The following is a description of a gene set: species: Homo sapiens The chemical reactions and pathways involving purine nucleobases, one of the two classes of nitrogen-containing ring compounds found in DNA and RNA, which include adenine and guanine. Human Gene Set: GOBP_PURINE_NUCLEOBASE_METABOLIC_PROCESS, and this is the list of marker genes: PPAT, URAD (NCBI Gene Id 651560), GART, PRTFDC1, PRPS1, TTR, GMPS, APRT, ADK, GMPR2, PAICS, GDA (NCBI Gene Id 9615), KDM1A, DPYD, ADA, ACP3, SHMT1, NT5C2, XDH, GMPR, HPRT1